Given this list of marker genes PCLAF, TCN1, BLVRA, CTSC, STMN1, IDH2, ALDH3B2, LGALS1, ITGB1, MMP10, MTHFD1, CBR1, ETV2, TK1, ASS1, PRCP, UBE2C, ATP1B3, MT1X, ESD, LIF, PLA2G4A, ASNS (NCBI Gene Id 440), SRD5A1, AKR1A1, MT1E, CDKN3, ITGA6, CIRBP, IFITM1, HNRNPA2B1, FGFBP1, H19, PAM, PCDHGC3, ACSL1, NCAPD2, YARS1, CRABP2, MMP1, CDC20, PPIB, SLC1A5, PLP2, RPL3, ADK, CEBPD, EXOSC7, AKR1C1 (NCBI Gene Id 9418), PGD, CKAP4, PLCD1, RSU1 (NCBI Gene Id 6251), TPP1, MALL, ODC1, PCK2, AARS1, MLH1, ATIC, CDC25B, VSNL1, EPHX2, PTMA, HMGB1, XBP1, GSN, HSD17B4 (NCBI Gene Id 3295), HSPA5, SDC1, here is a description of the gene set: Human Gene Set: SESTO_RESPONSE_TO_UV_C7 Cluster 7: genes changed in primary keratinocytes by UVB irradiation. from publication Sesto A, Navarro M, Burslem F, Jorcano JL (PMID 11867738) studied in species Homo sapiens UV radiation is the most important environmental skin aggressor, causing cancer and other problems. This paper reports the use of oligonucleotide microarray technology to determine changes in gene expression in human keratinocytes after UVB treatment. Examination of the effects of different doses at different times after irradiation gave a global picture of the keratinocyte response to this type of insult. Five hundred thirty-nine regulated transcripts were found and organized into nine different clusters depending on behavior patterns. Classification of these genes into 23 functional categories revealed that several biological processes are globally affected by UVB. In addition to confirming a majority up-regulation of the transcripts related to the UV-specific inflammatory and stress responses, significant increases were seen in the expression of genes involved in basal transcription, splicing, and translation as well as in the proteasome-mediated degradation category. On the other hand, those transcripts belonging to the metabolism and adhesion categories were strongly downregulated. These results demonstrate the complexity of the transcriptional profile of the UVB response, describe several cellular processes previously not known to be affected by UV irradiation, and serve as a basis for the global characterization of UV-regulated genes and pathways.